Given this list of marker genes VILL, ZBED4, CDK13, C1orf116, ZNF561 (zinc finger protein 561), MTURN, TRAPPC2B, SNHG15, SDHAP4, TMEM30B, SYNGR2, SAR1A, GAR1, SNHG1, INO80 (INO80 complex ATPase subunit), TNFRSF8, NOA1, JUNB, FBXL20, PANK1, TEKT4P2, ACSF2, ZBTB14, LGALS4, GABRP, here is a description of the gene set: DNA copy number alterations are believed to play a major role in the development and progression of human neoplasms. Although most of these genomic imbalances have been associated with dysregulation of individual genes, their large-scale transcriptional consequences remain unclear. Pancreatic carcinomas frequently display gene copy number variation of entire chromosomes as well as of chromosomal subregions. These changes range from homozygous deletions to high-level amplifications and are believed to constitute key genetic alterations in the cellular transformation of this tumor type. To investigate the transcriptional consequences of the most drastic genomic changes, that is, genomic amplifications, and to analyse the genome-wide transcriptional effects of DNA copy number changes, we performed expression profiling of 29 pancreatic carcinoma cell lines and compared the results with matching genomic profiling data. We show that a strong association between DNA copy numbers and mRNA expression levels is present in pancreatic cancer, and demonstrate that as much as 60% of the genes within highly amplified genomic regions display associated overexpression. Consequently, we identified 67 recurrently overexpressed genes located in seven precisely mapped commonly amplified regions. The presented findings indicate that more than one putative target gene may be of importance in most pancreatic cancer amplicons. Human Gene Set: HEIDENBLAD_AMPLICON_12P11_12_DN from publication Heidenblad M, Lindgren D, Veltman JA, Jonson T, Mahlamäki EH, Gorunova L, van Kessel AG, Schoenmakers EF, Höglund M (PMID 15688027) Down-regulated genes whose expression is associated with amplification of the 12p11-12 chromosome in pancreatic cancer cell lines. studied in species Homo sapiens